Given this list of marker genes Edn1, Ntrk1, Fgfr3, Nptx1 (NCBI Gene Id 18164), Itga4, Ece1, Col25a1, Sema3a, Ednra, Npr2, Nrp1, here is a description of the gene set: The neurite development process that generates a long process of a neuron, as it invades a target tissue. Mouse Gene Set: GOBP_AXONOGENESIS_INVOLVED_IN_INNERVATION species: Mus musculus